Given this list of marker genes MMAA, ARHGAP36, TASOR, PIGR, CLCC1, SLC43A3, LUZP1, MYOZ3, AHCTF1, SLC25A37, CRKL, FGF13, SLC6A15, SPMIP5, OPRM1, NDST2, TMEM132B, PNPLA1, CEP97, PLEKHS1, RECQL5, KPNB1, BROX, CDH2, PTPN11, KIAA1328, MYOZ2, SPTLC1, HSPA9, SLC46A1, MISP (NCBI Gene Id 126353), ATG2B, FNIP1, CENPA, SLC4A1, TRMT13, TCFL5, SPATA18, LRRC66, EDN1, PTPN2, PAOX, CHTF8 (NCBI Gene Id 54921), BNC2, SCAMP1, RASGRF1, DLG3, ITM2C, CHST11, MTF2, KLF3, KMT2D, GPSM2, PROX1, SETD9, NEGR1, ELF5, KLHL5, PORCN, ODF2L, NOTCH4, KIF19, POLR3D, CCL4, SFMBT1, SRF, ARAF, CCL4L2, COPG1, FLII, SIRT7, here is a description of the gene set: from publication Chen Y, Wang X (PMID 31504780) studied in species Homo sapiens Human Gene Set: MIR6729_3P Genes predicted to be targets of miRBase v22 microRNA hsa-miR-6729-3p in miRDB v6.0 with MirTarget v4 prediction scores > 80 (high confidence targets).